Given this list of marker genes Ddhd1, Nectin2, Vps13a, Mfsd14a, Septin4, Spata19, Nsun7, here is a description of the gene set: Mouse Gene Set: GOBP_SPERM_MITOCHONDRION_ORGANIZATION species: Mus musculus A process that is carried out at the cellular level which results in the assembly, arrangement of constituent parts, or disassembly of sperm mitochondria; the process in which they take on their characteristic morphology; they are flattened, elongated, and arranged circumferentially into a tight helical coil around the tail-dense fibers of the mature sperm.